The following is a description of a gene set: Mouse Gene Set: chr17B2 studied in species Mus musculus, and this is the list of marker genes: Mmut, Pgk2, Glyatl3, Esp6, Crisp2, Esp8, Esp4, Esp5, Tgif2-ps2, Gm20574, Ldha-ps3, Gm45926, Cenpq, Gm34266, Crisp1, Gm6771, Gm29748, Crisp3, Gm46573, 9130008F23Rik, Rhag, Gm44501, Esp1, Esp3